Given this list of marker genes PEX5, EBP, HSD17B4, PEX2, GNPAT, here is a description of the gene set: An abnormal punctate (speckled, dot-like) pattern of calcifications in soft tissues within or surrounding bones (as observed on radiographs). Calcific stippling Human Gene Set: HP_CALCIFIC_STIPPLING species: Homo sapiens